Given this list of marker genes SLX4, MSH6 (mutS homolog 6), AKT1, TRIP13, MAN1B1, PIK3CA, IL7, RAD51C, UBE2T, PTEN, MAP2K1, CEP57 (centrosomal protein 57), FANCI, BUB1B, USF3, PLXND1, CIB1, FANCB, RERE, FANCF, RAD51, MLH1, GNA11, TP63, PMS2, PALB2, BRCA2, ERCC4, SDHD, FANCC, SDHB, FANCL, REV3L (REV3 like, DNA directed polymerase zeta catalytic subunit), KDM5C, FANCA, XRCC2, KRAS, PCNT, BUB1, RFWD3, KLLN, BUB3, SPRED1 (sprouty related EVH1 domain containing 1), ARL6IP6, SEC23B, ATM, MAD2L2, ABCB6, FANCE, MSH2, PDE11A, FANCD2, TMC6, NF1, FANCG, SDHC, MAP2K2, PRKAR1A, BRAF, FANCM, BRCA1, TMC8, TWIST2, BRIP1, here is a description of the gene set: species: Homo sapiens Human Gene Set: HP_MULTIPLE_CAFE_AU_LAIT_SPOTS Multiple cafe-au-lait spots The presence of six or more cafe-au-lait spots.